The following is a description of a gene set: Human Gene Set: TAL1ALPHAE47_01 species: Homo sapiens Genes having at least one occurrence of the motif NNNAACAGATGKTNNN in the regions spanning 4 kb centered on their transcription starting sites. This matches the TAL1, TCF3 transcription factor binding site V$TAL1ALPHAE47_01 (v7.4 TRANSFAC)., and this is the list of marker genes: MAP7, HECTD1, OSM, NUFIP2, GPD1, TFAP2D, MBD6, SPATS1, SLC6A10P (solute carrier family 6 member 10, pseudogene), RHOBTB1, REPS2, E2F7, FBXW11, EHD4, SIX6, ELP5, CTDNEP1, C3orf20, HOXA1, PICALM, HCK, NSG2, TTN, ELMO1, MED13, ST6GALNAC5, HOXA11, ARPC1A, BRD4, KIRREL2, NPAS2, ABCD2, MSI1, ANGPTL1, NUMBL, MARCHF3, TFDP2, SCN5A, HAAO, MBNL2, TJAP1, GK, RCOR2, CDH2, CPNE1, GRM8, PNMA1, SLN, RNF133, C1QTNF4, RADIL, GABARAPL2, LIX1, NAA15, NDP, PRMT6, ARHGAP22, TP63 (tumor protein p63), KIF9, ARHGEF2, MRPL58, DAPK1, MEF2C, PMF1, FLNA, DDAH2, AFF3, EYA3, ONECUT2, SND1, OR10J1, PXYLP1, GFRA3, ELL2, TGFB3, PBXIP1, PDGFB, MARK1, ITGA8, SULT2A1, KDM4C, HOXC12, C7orf33, GLDN, TP53INP2, PABPC5, CD79B, CADM2, RNF19A, DCX, CPE, NABP2, JADE1, LIMA1, NKD1, TFAP4, MACF1, KCNJ2, GRID2, SYNPR, CHST9, NR6A1, FMNL3, ONECUT1, ZNF516-DT, NCKIPSD, SAP30L, SSH2, FOXP2 (forkhead box P2), MAF, PDE1A, DUSP10, UBQLN4, CCDC125, PLCB1, TSPAN13, SHOX2, STAG2, ITGBL1, BCL11B, B3GALT2, SELENOM, ARSG, RNF182 (ring finger protein 182), AMPH, RIOK3, LRRN1, ABHD16A, MYCLP1, ELF4, FAP (NCBI Gene Id 2191), ACLY, INHBE, TMEM71, INKA1, SIM1, ACVR1, WWC1, WDR81 (WD repeat domain 81), SOBP, C2CD5, PTGR3, ARL4A, PCDH1, HES6, PHOX2B, KLHL18, OGT, FGF9, NEUROD2, SULF1, SRPX2, RUNX1T1, SCGN, EXOC6, SH3KBP1, CDK19, SEMA6D, NAV3, ARRDC3, PDE4B, GPR173, GFRA1, KERA, HTR2C, SOX12, NDUFA4L2, ZMYND8, TMEM131L, IKZF2, TRIM37, SWAP70 (switching B cell complex subunit SWAP70), HEXIM2, PDLIM4 (NCBI Gene Id 8572), MAP1A, DTX2, FGF7, FHL3, KMT2E, SEL1L3, TSKU, SLC2A12, ATG12, GFI1, PRMT3, ZNF821, DDIT3 (DNA damage inducible transcript 3), LRRC42, ASB4, RCAN2, MIR22HG, HRK, RAB30, WNT6, GTDC1, TAC1, STK3, ALDH1A1, TPH2, NHLH1, DARS1, CDC42EP4, MAP2, GJB2 (gap junction protein beta 2), TAFA1, PRG4, CLVS1, SCN1B, TRIM3, ELAVL4, TCF12, FOXP1, NXPH4, STARD13, RAG2, CHRNG, PHEX, NTF3, C17orf58, PHACTR3, BANF2 (NCBI Gene Id 284779), NPR2, LRRN2, PI15, LTBP1, FBXO16, STAG1, CDH6, MRPL11 (NCBI Gene Id 65003), HID1, STC2, PCDH12, NEUROD6, UBXN10, LAMTOR2, DLL4, KLHL35, OMA1, YTHDC1, CBFA2T3, DMD, EIF3A, AP3S1, ATOH7, ADGRL2, ZNF710, CDH23 (NCBI Gene Id 7395), GNAS (NCBI Gene Id 82944), SMAD3, NXPH3, PHF21B, TC2N (tandem C2 domains, nuclear), KCNQ1DN, HTR7, RAB27A, ZBTB18, NHLH2